The following is a description of a gene set: The series of molecular signals initiated by an extracellular ligand binding to a receptor on the surface of the target cell capable of inhibiting an immune response. species: Homo sapiens Human Gene Set: GOBP_IMMUNE_RESPONSE_INHIBITING_CELL_SURFACE_RECEPTOR_SIGNALING_PATHWAY, and this is the list of marker genes: KIR2DL1, CLEC12B, LILRB1 (leukocyte immunoglobulin like receptor B1), KLRC1, LYN, LILRB2, HLA-G, PSG9 (pregnancy specific beta-1-glycoprotein 9), LILRB4